Given this list of marker genes COL1A1, TGFBR2, PLOD3, COL5A2, BICC1, TONSL, PKD1, MFAP5, FOXE3, HEY2 (NCBI Gene Id 30830), ALG5, IFT140 (NCBI Gene Id 9742), ENG, PCNT, MAT2A, TGFB2, ELN, STAT1, NF1, TGFB3, PKD2, PRKG1, SPTBN1, TGFBR1, SEC63, MYH11, COL4A1, APOA1, GAA, GGCX, TGFBR3, IPO8, THSD4, PRKAR1A, FBN1, COL5A1, MYLK, PRKCSH, SMAD4, PDE11A, ALG9, THSD1, COL3A1, LRP5, FARSB, GANAB, BGN, SMAD2, ANGPTL6, LOX (NCBI Gene Id 4015), ACTA2, SMAD3, DNAJB11, here is a description of the gene set: Human Gene Set: HP_DILATATION_OF_THE_CEREBRAL_ARTERY The presence of a localized dilatation or ballooning of a cerebral artery. Dilatation of the cerebral artery studied in species Homo sapiens